The following is a description of a gene set: Human Gene Set: GOBP_REGULATION_OF_INTEGRIN_ACTIVATION Any process that modulates the frequency, rate, or extent of integrin activation. species: Homo sapiens, and this is the list of marker genes: PTGER4, FARP2, SELP, FERMT1, P2RY12, CXCL13, RASIP1, FBLIM1, KIF14, SKAP1, CDH17, PIEZO1, JAM3, RAP1B, SRC, PLEK, FERMT2